Given this list of marker genes Rabgap1l, Ndrg3, Noc3l, Spart, Psmd3, Sergef, Scnm1, Ctu2, Tom1, Prnp, Klhl28, Dvl2, Tnfaip8, here is a description of the gene set: Mouse Gene Set: CUI_MAST_CELL_TRAIL_RESPONSE_UP from publication Cui A, Huang T, Li S, Ma A, Pérez JL, Sander C, Keskin DB, Wu CJ, Fraenkel E, Hacohen N (PMID 38057668) studied in species Mus musculus Cytokines mediate cell-cell communication in the immune system and represent important therapeutic targets. A myriad of studies have highlighted their central role in immune function, yet we lack a global view of the cellular responses of each immune cell type to each cytokine. To address this gap, the authors created the Immune Dictionary, a compendium of single-cell transcriptomic profiles of more than 17 immune cell types in response to each of 86 cytokines (>1,400 cytokine-cell type combinations) in mouse lymph nodes in vivo. A cytokine-centric view of the dictionary revealed that most cytokines induce highly cell-type-specific responses. For example, the inflammatory cytokine interleukin-1β induces distinct gene programmes in almost every cell type. A cell-type-centric view of the dictionary identified more than 66 cytokine-driven cellular polarization states across immune cell types, including previously uncharacterized states such as an interleukin-18-induced polyfunctional natural killer cell state. Genes positively differentially expressed in cell type: Mast cell upon treatment with cytokine: TRAIL in mouse lymph nodes in vivo.